Given this list of marker genes ZC3H12A, UBXN1, TANK, TRIM21, TNIP1, VCP, ITCH, NOP53, DNAJB2, OTUD4, PARK7, here is a description of the gene set: Any process that modulates the frequency, rate or extent of protein deubiquitination. Protein deubiquitination is the removal of one or more ubiquitin groups from a protein. studied in species Homo sapiens Human Gene Set: GOBP_REGULATION_OF_PROTEIN_DEUBIQUITINATION